Given this list of marker genes AGO1, TNRC6B, NR3C1, KCNIP3, MOV10, AGO2, NPAS4, AGO3, TNRC6C, SRF, REST, AGO4, TNRC6A, here is a description of the gene set: Human Gene Set: REACTOME_REGULATION_OF_NPAS4_GENE_EXPRESSION species: Homo sapiens Regulation of NPAS4 gene expression